The following is a description of a gene set: Inflammation of the thyroid gland. Thyroiditis studied in species Homo sapiens Human Gene Set: HP_THYROIDITIS, and this is the list of marker genes: GPR35, STAT5B, CDKN1B, ZFAT, PI4KA, FOXN1, MYT1L, SEC23B, PTEN, ADA, ADA2, TTC7A, CLCNKB, NLRP1, TG, SEMA4D, MST1, HLA-DQA1, SLC37A4, TBX2, C1S, CHD7, POLG, FASLG, FOXP3, PLCG2, SLC12A3, LIG4, FOXD3, FAS, IL18BP, IL2RA, DCLRE1C, CTLA4, RMRP, CASP10, NFKB2, TCF4, AKT1, HLA-DQB1, IL2RG, IL7R, ITCH, STAT1, RAG1, SOCS1, PIK3CA, RAG2, LRBA